The following is a description of a gene set: Binding to a protein phosphatase 2B. studied in species Mus musculus Mouse Gene Set: GOMF_PROTEIN_PHOSPHATASE_2B_BINDING, and this is the list of marker genes: Slc9a1, Ppp3cb (NCBI Gene Id 66215), Cacng8, Bad, Akap1, Atp2b4, Akap5, Cabin1, Sod1